The following is a description of a gene set: Mouse Gene Set: GOBP_REGULATION_OF_MACROPHAGE_ACTIVATION studied in species Mus musculus Any process that modulates the frequency or rate of macrophage activation., and this is the list of marker genes: Cd84, Il4ra, Ctsc, Pla2g5, Raet1d, Rora, Fam76b, Myo18a, Il13, Kcnn4, Cebpa, Lbp, Cx3cl1, Hspa4, Tlr4, Calhm2 (calcium homeostasis modulator family member 2), Mmp8, Slc7a2, Trem2, Adgrf5, Tafa3, Jund, Lgals9, Il1rl1, Ulbp1, Mcub, Cd1d1, Kars1, Sphk1, Il4 (interleukin 4), Tlr6, Il33 (NCBI Gene Id 77125), Tff2, Stap1, Bpi, Lrfn5, Wnt5a, Lrrk2, Nr1h3, Irgm1, Cd200 (CD200 molecule), Snca, Ttbk1, Pla2g10, Hamp, Cst7, Thbs1 (NCBI Gene Id 21825), Nr1d1, Mfhas1, Atm, Grn, Pparg, Hspd1 (heat shock protein 1 (chaperonin)), Pla2g4a, Il10 (interleukin 10), Muc5b, Gpr137b, Havcr2, Syt11, Shpk, Pja2, Tnip2, Ldlr